The following is a description of a gene set: Mouse Gene Set: GOMF_DIOXYGENASE_ACTIVITY studied in species Mus musculus Catalysis of an oxidation-reduction (redox) reaction in which both atoms of oxygen from one molecule of O2 are incorporated into the (reduced) product(s) of the reaction. The two atoms of oxygen may be distributed between two different products., and this is the list of marker genes: Kdm8, Alkbh8, Kdm5d, Ogfod2, Hspbap1, Alkbh2 (NCBI Gene Id 231642), Egln2, P4ha3, Fto, Kdm4d, Ido2, Tyw5, Alkbh4, Alox8, Jmjd6, Kdm1b, Alox12b, Rpe65, Egln1, Por, Ethe1, Pir, Alox12e, P4htm, Kdm3b, Riox2, Ogfod3, Phyhd1, P4ha1, Hgd, Alkbh6, Hpdl, Alkbh7, Haao, P3h3, Kdm2a, Plod3, Jmjd1c, Kdm1a, Phf2, Kdm6b, Kdm4b, Alox5ap (NCBI Gene Id 11690), Tet3, Egln3, Alox15, Alkbh1, Bco2, Uty, Jmjd4, Alkbh3, Ogfod1, Hpd, Kdm5b, Kdm3a, Kdm4a (NCBI Gene Id 52239), Tdo2, Asph, Bco1, Tet1, Jmjd7, Kdm7a (lysine (K)-specific demethylase 7A), Kdm6a (lysine (K)-specific demethylase 6A), Hif1an, Kdm2b, Plod1, Alox5, P3h1, Hr, Tet2, Asphd1 (NCBI Gene Id 233879), Asphd2, P4hb, Ptgs1, P3h2 (NCBI Gene Id 210530), Rsbn1, Plod2, Kdm4c, Ptgs2, Ido1, Aloxe3, Riox1, P4ha2, Kdm5c, Alkbh5, Cdo1, Adi1, Phf8, Ado, Alox12, Bbox1, Kdm5a, Phyh